Given this list of marker genes LGALS1, VDAC3, GARS1, KCTD9, TAF6 (TATA-box binding protein associated factor 6, NCBI Gene Id 6878), BLMH, RBM34, POLA2, API5, ADD1, SF3A3, BSPRY, RAD18, FAM111A, NDUFS8, NDUFA2, MAGOH, DNAJB11, TRPC4AP, DLD, CHMP2A (NCBI Gene Id 27243), DNPH1, NSF, H1-2, CCDC34, AP2B1, PSMD8, ECH1, MED23, PLPP3, BCAT1, DEPDC1, PGD, RACGAP1, RBBP7, ZBTB8OS, TDP1, CWC15, HAUS8, GNPNAT1, CENPC, ZFP69, CDKN2C, CHEK2, TIMELESS, NEIL3, LSM2, S100A10, ALG8, CKS2, HROB, DBI, FIGNL1, CIT, SARS1, FANCB, IL1RL1, BUB1, LCP1, HNRNPC, DPY30, GINS3, ESPL1, NEK2, IFT27, TUBA1A, PGK1, TMEM218, KRT13, KLHDC10, NUCKS1, CDK4 (cyclin dependent kinase 4), CDCA5, EIF3C, BARD1, GTF2H5, MYL11, CCDC18, YBX1, ALYREF, IPO8, DSN1, GNAI2, PPIA, LIG1, TAF2, ELOF1, GLA, PSAT1, KMT5A, ZCCHC8, WDHD1, PMM1, SIVA1, TAF5, TK1 (thymidine kinase 1), NDUFAF2, GMNN, TUBB2A, ANP32E, LANCL2, RANGAP1, ME2, UBE2T, NCAPG2, ARHGDIA, MIS12, H4C9, LRR1, ORC6, POC1A, ACSL5, CCDC50, EIF2S2, PSMB5, CENPI, LARP7, TOMM6, EPRS1, PSMA6, FAM72A, MME, GINS4, CALM3, PABPC1, ATP5F1A, IPO5, RPS2, NUP155, EEF1G, KIF24, COX7A1, CXCR4, COX6B1, PPP4C, CBFB, UBE2S, HSPA5, KNTC1, SPATA24, PSMG1, DSCC1, UHRF1, UQCRC1, RFC2, MRPL42, MAD2L1, MRPS21, PSMC3IP, CLDND1 (NCBI Gene Id 56650), MNS1, WDR1, DEK, GLTP, NELFCD, EHD1, MROH2A, SPDL1, RBM44, NMRAL1, MIPEP, UGDH (UDP-glucose 6-dehydrogenase), PTPN6, COX5A, E2F3, PLK4, SGO1, ENDOD1, PRPF40A, EIF1AX, PCBP1 (NCBI Gene Id 5093), here is a description of the gene set: from publication Gratchev A, Kzhyshkowska J, Kannookadan S, Ochsenreiter M, Popova A, Yu X, Mamidi S, Stonehouse-Usselmann E, Muller-Molinet I, Gooi L, Goerdt S (PMID 18453574) The goal of the study was to identify the effects of TGF-beta on primary human macrophages maturated under different conditions. Genes up-regulated in macrophages differentiated for 5 days in the presence of: IL4 versus IL4 and dexamethasone. Human Gene Set: GSE7568_IL4_VS_IL4_AND_DEXAMETHASONE_TREATED_MACROPHAGE_UP studied in species Homo sapiens